The following is a description of a gene set: studied in species Homo sapiens Human Gene Set: GOBP_HEPARIN_PROTEOGLYCAN_METABOLIC_PROCESS The chemical reactions and pathways involving heparin proteoglycans, which consist of a core protein linked to a heparin glycosaminoglycan. The heparin chain is composed of the repeating disaccharide unit beta-(1,4)-N-acetyl-D-glucosamine-alpha-(1,4)-hexuronic acid, the former being either sulfated or deacetylated on its amino group as well as sulfated on one of its hydroxyl groups, and the latter being e a mixture of sulfated and nonsulfated D-glucuronic and L-iduronic acids. Heparin is similar to heparan sulfate but it contains more N-sulfate and O-sulfate groups. Heparin proteoglycans are stored selectively in the secretory granules of mammalian mast cells., and this is the list of marker genes: HS2ST1, EXT2, NDST2, EDNRA, NDST1, NDST4, EDNRB, GLCE, NAGLU, XYLT2, HPSE, CSGALNACT1, ANGPT1, NDST3, EXT1, IDUA, SLC10A7